The following is a description of a gene set: studied in species Homo sapiens Our data indicated that activation of the PPARg nuclear receptor induces a retinoid response in human dendritic cells. In order to assess the contribution of retinoid signaling to the PPARg response we decided to use a combination of pharmacological activators and inhibitors of these pathways. Cells were treated with the synthetic PPARg ligand rosiglitazone (RSG), or with RSG along with the RARa antagonist (AGN193109) to block RARa mediated gene expression, or the RARa specific agonists (AM580) alone. This design allows one to determine if retinoid signaling is a downstream event of PPARg activation and what portion of PPARg regulated genes are regulated via induced retinoid signaling. from publication Szatmari I, Pap A, Rühl R, Ma JX, Illarionov PA, Besra GS, Rajnavolgyi E, Dezso B, Nagy L (PMID 16982809) Human Gene Set: GSE5679_CTRL_VS_RARA_AGONIST_AM580_TREATED_DC_DN Genes down-regulated in monocyte-derived dendritic cells: untreated versus AM580., and this is the list of marker genes: ETS1, MAP3K3, ZFP62, TNFAIP1, COL27A1, GIMAP8, MATN2, ITGA2B, CRLF3, NIBAN1, APBB1, CLCF1, DDB2, PLCB4, BICRAL, DIP2A, PIGH, NEIL1, H3-5, ELAC1 (elaC ribonuclease Z 1), TRIM2, SNX13, MTURN, REXO5, SBSN, STAT5B, TXNRD3, OSBPL9, ZNF274, PTGER2, MIR22HG, BSDC1, TMEM191C, CARNS1, CCNL2, TMC4, BACH1, PRPF39, AHNAK (NCBI Gene Id 79026), ERGIC2, PCYT1B, RFX3, TTYH2, SH3BGRL (SH3 domain binding glutamate rich protein like), POLG, GPR137B, PRSS41 (NCBI Gene Id 360226), DNAJC12, FAM193B, SCAPER, CSNK1E, RAB6B, ANKRD6, RIC8A, ZNF786, NR3C2, RGL2 (ral guanine nucleotide dissociation stimulator like 2), ITGB8, ZBTB20, ARIH2, SYTL2, MICU3, MALT1, MARVELD1, ATRX, GM2A, ANKLE2, KANSL1L, MYO1F, PSTPIP2, CEP68, YPEL3, KIAA0232, TJP2, PJA1, DUSP1, WASL, MAN2A2, ATP6V0D2, EML5, ACSBG1, TRIP6, FBXO22, OTUD1, SKIL, PIGP, PLCL1, CISD2, INPP5F, LATS2, CAPN15, SLC17A5, MAN2C1, PIK3R1, CHDH, TMOD1, IPMK, PYROXD1, SHOC2, TMC6, MATK, SLC25A24, ZBTB2, ZNF827, STX16, PANK1, RAB3GAP1, FCSK, PDE4DIP, TAX1BP3, CLCN2, CAMK2N1, FHIP1A, VAMP3, LCLAT1, CHMP1B, FRMD6 (NCBI Gene Id 122786), ARID4A, MTX3 (metaxin 3), TCTA, HLA-B, INPP4B, ANKRD16, CCNDBP1, MNT, RORA, DCAF6, PLD2, ARHGAP45, PITPNM1, SLC20A2, TERT, AIRN, SMIM14, PHLPP1, RNASE4, UNC45A, CIZ1, DGAT1, FAAH, FAM53B, PLAGL1, CREB3L2, CIR1, MKRN1, TMEM181, B4GALNT4, SH3BGRL2, FLCN, KRAS, RASGEF1A, HERPUD2, TRIM11, CATSPERD, SH2B1, MTMR11, VSIG10, DNAJA4, PAXBP1, GPR155, GRAMD1A, KLF7, PHYHD1, FOXO4, FPGT, IKZF2, TUT4, LEMD2, PTPN13, PPOX, SLC35D1, FHIP2B (FHF complex subunit HOOK interacting protein 2B), TUBB2A, CREBZF, OAZ2, ARMCX2 (NCBI Gene Id 9823), LETM2, TTL, GCLC, RHEBL1, RNASET2, IQGAP1, PTTG1, TIAM1, ICE1, STX1A, ZNF862, PEAR1, KHNYN, NTN4, HABP4, CCDC82, TNFAIP3, PINK1, PTTG1IP, L1CAM, PIP4K2B, KDM3B, PRKAG2, WDR38